Given this list of marker genes Zmynd8, Grin1, Ins1, Apoe, Ins2, Nedd9, Zfp804a, here is a description of the gene set: Mouse Gene Set: GOBP_POSITIVE_REGULATION_OF_DENDRITIC_SPINE_MAINTENANCE species: Mus musculus Any process that activates or increases the frequency, rate or extent of dendritic spine maintenance.